Given this list of marker genes Fcgr4, Ighe, H2-T23, Fcgr3, Fcer1g, Ighg2b, Fcgr2b, Ighg1, Fcgr1, C3, here is a description of the gene set: An inflammatory response resulting in cell death or dysfunction mediated by activation of the classical complement pathway or induction of effector cell phagocytosis, cytolysis mechanisms via complement or Fc receptors following the binding of antibodies to cell surface antigens on a target cell, or mediated by the direct binding of antibody to cellular receptors. species: Mus musculus Mouse Gene Set: GOBP_TYPE_II_HYPERSENSITIVITY